The following is a description of a gene set: species: Homo sapiens Human Gene Set: GOBP_NUCLEOBASE_BIOSYNTHETIC_PROCESS The chemical reactions and pathways resulting in the formation of a nucleobase, a nitrogenous base that is a constituent of a nucleic acid., and this is the list of marker genes: APRT, CTPS2, CPS1, PPAT, PRPS1, GART, DHODH, UMPS, MTOR, CAD, PAICS, SHMT1, CMPK1, HPRT1, CTPS1, ADA, GMPS, PRTFDC1